The following is a description of a gene set: studied in species Mus musculus The expansion of a T cell population by cell division. Follows T cell activation. Mouse Gene Set: GOBP_T_CELL_PROLIFERATION, and this is the list of marker genes: Satb1, Ceacam1, Rps6, Lgals9, Lmbr1l, Il2, Cd244a, Casp3, Irf1, Igfbp2, Tnfsf13b, Prkcq, Zp3, Itgax, Adk, Tnfrsf14, Erbb2, Spn, Slamf1, Ephb6, Igf1, Spta1, Slfn1, Ccr7, Carmil2, Bax, Jak2, Pla2g5, Il15, Tspan32, Trp53, Il27, Hes1, Bcl6, Zc3h12d, Cblb, Vtcn1, Il1b, Alkbh5, Ebi3, Muc19, Ctnnb1, Washc1, Lilrb4a, Tnfsf4, Dhps, Ppp3ca, Efnb1, Cd209a (NCBI Gene Id 170786), Foxp3, Itgam, Ripk3, Prnp, Malt1, Il4, Gja1, Ptpn6, Fyn, Blm, Cd3e, Itgad, Tgfbr2, Cd1d2, Ccdc88b, Hmgb1, Nck1, Fkbp1a, Lilrb4b, Dock2, Nck2, Dock8, Il2ra, Sos2, Cd40lg, Prdx2 (peroxiredoxin 2), Zbtb7b, Psmb10, Aif1, Crip3, Cd55b, Irgm1, Btnl2, Tyk2, Sash3, Tnfrsf4, Zap70, Anxa1, Elf4 (NCBI Gene Id 56501), Bmp4, Arg2, Cd151, Cd276, Scgb1a1, Cd24a, H2-T23, Sos1, Tnfsf18, Il6, Vsig4, Pla2g2f, Cd209c, Nr5a2, Sdc4, Cd81, Il18, Il23a, Slc7a1, Selenok, Cd37, Cd6 (CD6 antigen), Cd44, Il12b, Tarm1, Cxcl12, Il12a, Lep, Ptprc, Cd1d1, Dnaja3 (DnaJ heat shock protein family (Hsp40) member A3), Il12rb1, Pdcd1lg2, Slc4a2, Clec2i, Cd80, Btla, Ncstn, Pla2g2a, Shh, Tnfrsf13c, Itch, Tfrc, Card11, Cxcr4, Prkar1a, Sh2d2a, Ifnar2, Tnfrsf21, Sh3rf1, Ihh, Fkbp1b, Stat5a, Cdkn2a, Clec4g, Kitl, Arg1 (NCBI Gene Id 11846), Tnfrsf1b, Tnfrsf9, Rasgrp1, Coro1a, Lmo1, Zbtb32 (NCBI Gene Id 80652), Vsir, Slc11a1, Ctla4, H2-DMb1, Pawr, Rc3h2 (ring finger and CCCH-type zinc finger domains 2), Abl1, Il20rb, Twsg1, Pten, Mad1l1, Bmi1, H2-DMb2, Cd4 (NCBI Gene Id 212762), Havcr2, Cd59a (NCBI Gene Id 98841), Cd274, Tsc2, Cd46, Scrib (scribbled planar cell polarity), Igf2, Ccl19, Slc4a1, Cd70, Laptm5, H2-M3, Armc5, Itgb2, Ptpn22, Rc3h1, Peli1, Znhit1, Stat5b, Cd55, Il3, Ndfip1, Cd28, Crtam, Icosl, Ido1, Fadd, Il4i1, Lipa, Tmem131l, Tgfb1, Il1a (NCBI Gene Id 16175), Mapk8ip1, Ccl5, Btn2a2, Traf6, Cd209e, Ccnd3, Cd209d, Vcam1, Cd86, Nckap1l, Pnp, P2rx7, Tnfsf9, Il6st, Ripk2, Cebpb (CCAAT/enhancer binding protein beta), Ager, Rps3, Itgal, Dlg1, Xcl1, Rac2, Pla2g2d, Lrrc32, Jak3, Ctps1, Sftpd, Epo, Pycard, Rasal3, Myc, Syk, Bid, Msn, Foxj1, Gnrh1, Pde5a, Cd59b, Wnt4, Gpnmb, Ccr2 (NCBI Gene Id 235692), Glmn, Ripor2, Ifng, H2-Aa, Dlg5, Slfn2, Marchf7, Lgals3, Il21, Gpam